The following is a description of a gene set: Genes predicted to be targets of miRBase v22 microRNA mmu_miR_6339 in miRDB v6.0 with MirTarget v4 prediction scores > 80 (high confidence targets). Mouse Gene Set: MIR_6339 species: Mus musculus from publication Chen Y, Wang X (PMID 31504780), and this is the list of marker genes: Loxl2, Hycc2, Ap3s1, Eid2b, Hps3 (HPS3, biogenesis of lysosomal organelles complex 2 subunit 1), Prpf4b, Dclk1, Rc3h2, Gatm, Nab1, Eif1ad7, Sestd1, Atp2c1, 2310039H08Rik, Sft2d3, Rcor1, Slc25a46, Eif1a, Slc10a2, Smarcc1, Frs2, Pls3, Osbpl11, Tab3, Srrm2, Tex13c1, Cyp2c50, Nkd1, Atrnl1, Pygo1, Kras (Kirsten rat sarcoma viral oncogene homolog), Kcnk10, Calhm5, Ubl3, Eif1ad3, Bhlhb9 (NCBI Gene Id 70237), Faap24, Acbd5, Rab11a, Crppa, Fmo9, Cdk6, Mblac2, Cep97, Sub1, Cenpu, Atrx, Naf1, Mob1a, Serpinb13, Klf13, Epha4, Rad51b, Abcd2, Raver2, Emc1